The following is a description of a gene set: Reactome Pathway: Metabolism of ingested SeMet, Sec, MeSec into H2Se part of: Selenoamino acid metabolism Inorganic (selenite, SeO3(2-); and selenate, SeO4(2-)) and organic (selenocysteine, Sec; and selenomethionine, SeMet) forms of selenium can introduced in the diet where they are transformed into the intermediate selenide (Se(2-)) through the trans-selenation pathway, selenocysteine lyase (SCLY), and cystathionine gamma-lyase (CTH). studied in species Homo sapiens, and this is the list of marker genes: SCLY, CBS, CTH, MAT1A, HNMT, NNMT, AHCY (NCBI Gene Id 191), GNMT